Given this list of marker genes FASLG, TBC1D4, HDAC2, BCL7A, LARP4, ASAP1, SKP2 (S-phase kinase associated protein 2), MTDH (NCBI Gene Id 92140), DIDO1, NRP1, DYNLL2, PLXND1, TNFSF4, LRPPRC, GPATCH4, TRIB1 (NCBI Gene Id 80272), CTPS1, ELL2, PRMT3, STARD9, C3orf80, PLPP1, SOCS5, SELENOI, TSR1, GSPT2, PPP3CA, C2CD3, CD96, IL6, FAM98B, SWAP70, FANCF, ABITRAM, BEND3, THOC7, LRATD1, RFWD3, NUP85, SAMSN1, SKIC8, IL15RA, P2RY14, ERMP1, PTER, PTPN11, TTYH3, USP15, GTF2H1, SERPINE2, OBI1, LYPD6B, SLC23A2, NDC1, PENK, MTREX, NAF1, GSTO1, FKBP3, NDUFA12, NUP107, SLC16A1, CD83, CAPN3, CD1D, POP1, AKAP8, EOMES, AEN, SNRNP40, PLA1A, SHQ1, METTL17, MCM5, UTP20, BEX1, ZNF600, RAD50, LRIF1, FEN1, BLZF1, SH3BP5, DERA, TXNL4A, RFC5, DBR1, IL10RB, MOAP1, KCNQ5, TSR2, HGH1, MTRR, NDUFAF4, CDC25A, WDR3, ELP1, RPIA, PHLDA1, ISG20L2, DHX33, ERGIC1, CMTM7, TLK1, SARNP, NHLRC2, COMTD1, AP1S3, ZNF280B, PTCD3, STYX, DDX3X, PUS7L, TTC27, ANKRD49, TASL, PLCXD2, ABRACL, RPP14, GPR34, FAM111A, ADK, NUCKS1, ASF1A, RIOK2, CCNE2, NEFH, DNAH7, KYAT3, RPN1, EGR3, ADNP, DNAJA1, RHOD, CBX1, IGFLR1, PTGER4, RBMXL1, DNA2, TIPIN, CTSS, PPAN, ATP8B4, DFFB, CD81, RCSD1, ORC2, LIN7A, TBP (NCBI Gene Id 6908), ATP11C, ITGB1, CCT3, WDR77, C12orf75, EXO1, SIDT1, HNRNPU, SHTN1, PHLDA3, BUB3 (NCBI Gene Id 9184), MIX23, THAP1, ARFGAP2, CISD2, DR1, MSL2, ELP2, RPF2, RPA2, FAP, CARNMT1, SVIP, CSN2, PSMC2, GPN1, ATAD3A, HOMEZ, POLR1F, METAP2, HSPD1 (NCBI Gene Id 56733), AIM2, INSIG1, BID, TNNI1, PDCD1LG2, FAR1, SOWAHC, SLC4A7, SEC11C, TBRG4, CITED2, RUVBL1, BZW2, DCUN1D3, ENO3, UBE2E1, ACSL1, ALG8, PSMD11, PSMA5, KLHDC3 (NCBI Gene Id 116138), here is a description of the gene set: from publication Lee Y, Awasthi A, Yosef N, Quintana FJ, Xiao S, Peters A, Wu C, Kleinewietfeld M, Kunder S, Hafler DA, Sobel RA, Regev A, Kuchroo VK (PMID 22961052) species: Homo sapiens Genes up-regulated in comparison of untreated CD4 T cells versus those treated with TGFB3 IL6. TGF-beta3 produced by developing Th17 cells induces highly pathogenic T cells that are functionally and molecularly distinct from TGF-beta1-induced Th17 cells. The microarray data represent a distinct molecular signature for pathogenic versus non-pathogenic Th17 cells. Human Gene Set: GSE39820_CTRL_VS_TGFBETA3_IL6_CD4_TCELL_UP